Given this list of marker genes Fastkd2, Nop53, Rcc1l, Ddx28, Rpf2, Rpl11, Rpl5, Mdn1, Nop2, Bop1, Mrm2, Rrs1, Eif6, Dhx30, Mrto4, Rpl24, Brix1, Rpl10l, mt-Rnr2, here is a description of the gene set: Mouse Gene Set: GOBP_RIBOSOMAL_LARGE_SUBUNIT_ASSEMBLY studied in species Mus musculus The aggregation, arrangement and bonding together of constituent RNAs and proteins to form the large ribosomal subunit.